Given this list of marker genes GRIP1, ROBO1, MKS1 (MKS transition zone complex subunit 1), ALG9, WNT4, MBTPS2, CCNQ, MED12, here is a description of the gene set: Human Gene Set: HP_HYPOPLASIA_OF_THE_BLADDER Hypoplasia of the bladder studied in species Homo sapiens Underdevelopment of the urinary bladder.